Given this list of marker genes ENO1, esxA, PGK1, here is a description of the gene set: studied in species Homo sapiens Mtb secretes proteins that enhance enzymatic activity of glucose metabolism in the phagocyte. The same proteins also appear to increase glucose uptake and to cause accumulation of DHAP, ultimately increasing the host cell's lipid production. Reactome Pathway: Manipulation of host energy metabolism part of: Response of Mtb to phagocytosis